The following is a description of a gene set: Human Gene Set: GOMF_CO_RECEPTOR_BINDING Binding to a coreceptor. A coreceptor acts in cooperation with a primary receptor to transmit a signal within the cell. species: Homo sapiens, and this is the list of marker genes: HFE, DKK3, BMP4, WNT3A, TFR2, DKK2 (dickkopf WNT signaling pathway inhibitor 2), DKK4, LRRK2, BMP2, DKK1, NEO1, DKKL1, WNT9B